The following is a description of a gene set: The multiplication or reproduction of satellite cells, resulting in the expansion of the cell population. Satellite cells are quiescent cells that are located between the basal lamina and the plasmalemma of the muscle fiber, which are the main contributors to postnatal muscle growth. In adult muscle, satellite cells become activated to divide and differentiate in response to muscle damage. Mouse Gene Set: GOBP_SKELETAL_MUSCLE_SATELLITE_CELL_PROLIFERATION studied in species Mus musculus, and this is the list of marker genes: Mstn, Sugt1, Myog, Rtl1, Megf10, Ndc80, Cflar, Akirin1, Ephb1, Snhg15, Ppard, Stat3, Jak2, Six5, Kpna1, Six1, Dsn1, Angpt1, Paxbp1, Fgf2 (NCBI Gene Id 14173)